Given this list of marker genes GREM1, CER1, GREM2, DDIT3, ACVR1, NBL1, MICOS10-NBL1, AIDA, WNT8B, SOSTDC1, CTNNB1, here is a description of the gene set: Human Gene Set: GOBP_DETERMINATION_OF_DORSAL_VENTRAL_ASYMMETRY Determination of asymmetry from the dorsal to the ventral side; as, the dorsoventral axis. studied in species Homo sapiens